The following is a description of a gene set: The action of a molecule that contributes to the structural integrity of a presynaptic active zone. Human Gene Set: GOMF_STRUCTURAL_CONSTITUENT_OF_PRESYNAPTIC_ACTIVE_ZONE studied in species Homo sapiens, and this is the list of marker genes: PCLO (piccolo presynaptic cytomatrix protein), ERC1 (NCBI Gene Id 84770), BSN, ERC2, RIMS2, RIMS3, RIMS1